Given this list of marker genes MGME1 (NCBI Gene Id 92667), PLD3, EXO1, PLD4, EXO5, here is a description of the gene set: studied in species Homo sapiens Catalysis of the sequential cleavage of nucleotides (such as mononucleotides or dinucleotides) from a free 5' terminus of a single-stranded DNA molecule. Human Gene Set: GOMF_SINGLE_STRANDED_DNA_5_3_DNA_EXONUCLEASE_ACTIVITY